The following is a description of a gene set: Any process that activates or increases the frequency, rate or extent of leukocyte cell-cell adhesion. Human Gene Set: GOBP_POSITIVE_REGULATION_OF_LEUKOCYTE_CELL_CELL_ADHESION species: Homo sapiens, and this is the list of marker genes: IL2RA, RASAL3, ARID1B (NCBI Gene Id 645070), CSK, CD44, IL7, AP3B1, BRD4, CYLD, STAT5B, IL1A, GPAM, CD4, EBI3, CCR2, ACTL6A, JAK2, CBFB (core-binding factor subunit beta), FOXO3, TESPA1, CCL2, CARD11 (caspase recruitment domain family member 11), ABL2, IL4, CD74, XBP1, PCK1, NOD2 (NCBI Gene Id 8135), CD6, SOCS5, SOX12, CD86, VSIR, SYK, IL18, SELE, EFNB1, LILRB1, NFKBID, DPP4, FLOT2, ANXA1, IL12RB1, TGFBR2, FADD, DUSP10, ZAP70, HLA-DRB4, PHF10, IGFBP2 (insulin like growth factor binding protein 2), NR5A2, BAD, HLA-DRA, PTPN6, HLA-E, AP3D1, BCL10, CD5, LYN, GCNT1, PRKCZ, CYRIB, ALOX5 (NCBI Gene Id 240), BCL6, IL2RG, HLA-DOA, STAT5A, HLA-DMB, IL6, IL21, CD209, IL6ST, LGALS8, CR1, RHOH, CCL5, FOXP3, CCL21, PIK3R6, IL1RL2, HSPH1, TNF, SELENOK, VAV1, YES1, AKT1, RUNX3, HLA-DQA2, CD81, SELP, TMIGD2, CD274 (CD274 molecule), GPR65, CCDC88B, IL23A, VNN1, TNFSF9, ITGB2, HMGB1, PPP3CA, CD47, PYCARD, SPTA1, ICOS, MIR30B, TGFB1, HLA-DPB1, SMARCD2, VCAM1, BTN2A2, ACTB, KLHL22, ZP3, SLAMF1, TNFRSF13C, SIRPB1, KLRK1, TNFSF11, IL36B, CD28, IRAK1, HLA-G, FUT4, HLA-DPA1, WNT10B, CD40LG, LCK, RIPK2, RPS3, EP300, NFKBIZ, HLA-DMA, LGALS9, CD70, EPO, DHPS, SPN, SHH, IL4I1, SMARCD1, SIRPA, HLA-DRB5, SMARCA2, ITPKB, AGER, SHB, SIRPG, HAS2, ELANE, IGF1, BTNL2 (butyrophilin like 2), TYK2 (tyrosine kinase 2), ZMIZ1, BMI1, MALT1 (MALT1 paracaspase), CD55, SMARCE1, KAT5, PDCD1LG2, TFRC, SLC7A1, ABL1, HES1 (hes family bHLH transcription factor 1), ETS1, HAVCR2, SMARCD3, GLI3, CD83, NKAP, CD3E, SMARCC1, IHH, IL12B, CD27, IL7R, NLRP3, CD24, ARID1A, BRD7, CD46, HLA-DQB2, CAV1, ZBTB1, HLA-A, TNFSF4, HLA-DQB1, NCKAP1L, NFAT5, OPA1, NR4A3, NCK2, CCR7, TRAF6, SMARCB1, HHLA2, B2M, RUNX1, LEF1, LILRB2, BRD2, MIR92A1, RARA, IL23R, PTPRC, CCL19, DOCK8, GLI2, FYN, IFNG, SRC, RHOA, TNFSF14, CD80, ACTL6B, EFNB2, HLX, CD276, CORO1A, ARID2, THY1, ITGA4, SASH3, HSPD1, SOX13, KLRC4-KLRK1, TNFRSF14, SMARCA4, PBRM1, VTCN1, MIR21, HLA-DOB, IGF2, LILRB4, PRKAA1, XCL1, RASGRP1, CD1D, TNFSF13B, KITLG (NCBI Gene Id 780897), HLA-DQA1, FCHO1, IL4R, FBXO38, SART1, EFNB3, CLECL1P, GATA3, ADA, CHST4, AMBRA1, NCK1, RELA, SMARCC2, DNAJA3, FUT7, RAG1, PIK3CD, CHST2, IL12A, AIF1, SOX4, PDPK1, PTPN11, ZBTB16, LEP, PNP, LGALS1, CD160, IL15, YWHAG, SKAP1, ADAM8, MTOR, ICOSLG, ST3GAL4, HLA-DRB1, KLHL25, IL2, PRKCQ, EGR3, ZBTB7B, IL1B, MDK, HLA-DRB3, MAP3K8, SOCS1, ZP4